The following is a description of a gene set: Genes having at least one occurrence of the motif GNCCAWATAWGGMN in the regions spanning 4 kb centered on their transcription starting sites. This matches the SRF transcription factor binding site V$SRF_Q6 (v7.4 TRANSFAC). Human Gene Set: SRF_Q6 studied in species Homo sapiens, and this is the list of marker genes: NOL4, LDB3, EGR1, TLE3, KCNK3, FGF8, TRDN, RSF1, SYNCRIP, SRD5A2, SRF, RASSF2, LPP, ADAMTS12, FLNA (NCBI Gene Id 8272), NPR3, ARPC4, TRAF3IP2, MYLK, DMD, PRMT3, DVL3, DUSP2, PRDM1, SLC25A4, DUSP10 (NCBI Gene Id 11221), EGR2, LRP5, FOSB, MAPKAPK2, NPPA, DMPK, EPHB1, CHD6, ACTB, FOXP2, BLOC1S1, STAT5B, NPAS4, ZNF513, NNAT, KBTBD12, KRT17, IGF2-AS, H2AX, ALG10, FAM53C, SVIL, THBS1, MUS81, HAPSTR1, RIMS1, RARB, ITGB1BP2, PDLIM3, FAM83H, ZNF408, ABR, GPR20, LYRM1, ZEB1, CTDSP1, TRIM55, DIXDC1, LSP1, PITPNA, H3-3A, SCN3B, PLPP3, HOXD13, MYL6, GRK6 (NCBI Gene Id 2870), TPM2, IGF1, TNMD, JUNB, CNN1, EML4, HOXC5, ATP1A2, FOSL1, ASPH, AKIRIN2, AGL, TRIM46, MYL1, TMEM47, MAP3K20, SIN3A, PADI2 (peptidyl arginine deiminase 2), MYL9, HOXD10, DCUN1D3, SIX2 (SIX homeobox 2), PLCB3, TAGLN, ACKR1, FGFRL1, RUNDC1, LINC00311, MRGPRF, COL1A2, PLN, PRKAB2, RHOJ, AARSD1, NFATC4, STX10, BDNF, GNG8, G3BP2, FLAD1, FOXP1, FOXP3, LDLRAD4, CITED2, SP7, ACTA1, PHF12, HIVEP3, SLC7A1, RAP1A, UBE2D3, ACTC1, ZNF644, ACTR3, HOXB5, NKX2-1, MSRB1, LRRFIP1, HERC1, ADGRG4, PRM1, ACAA2, KRTCAP2, CFL2, RERE, MYO1E, MSX1, KIF1B, RBBP7, FBXL22, DGKG, FST, SETD2, SUN2, CDKN1B (NCBI Gene Id 1027), CSMD3, PPP1R12A, TAFAZZIN, KDM3A, NPAS2, ACTN1, ABL1, ROCK2, NKX6-1, SLC4A3, CABP1, CNTF, PODN, JPH2, FOXE3, CX3CL1, SCOC, TMEM126A, TPM3, SIPA1, IL17B, PRUNE2, HOXA1, NR2F1, MYH11, RSU1, HOXA5, HOXA3, CD248, PDLIM7, LRRTM4, NAV1, MYO18B, ELAVL4, CSNK1E, LDHA, PPP2R3A, HOXB4, PRR14L, ORAI3, CKM, MBNL1 (NCBI Gene Id 9850), KCNMB1, ITGA7, KLF6, PRELP, TFAP2D, EVA1C, NR2F2, AAMDC, KCNA1 (potassium voltage-gated channel subfamily A member 1), TGFB1I1, ACTG2 (actin gamma 2, smooth muscle), MYADM, INSM1, EMILIN2, PDLIM4, GADD45G, POU3F4, EPB41L4B, PCDH7, AQP2 (NCBI Gene Id 359), PTCH1, CALD1, PDLIM5, MYL7, TES (testin LIM domain protein), CNN2, CORO1C, ATF4, SUSD1, RAB27A, PPARG, COL1A1, DUSP5, EFHD1, MATR3, CAVIN2 (NCBI Gene Id 8436), FOS, PFN1, CACNA1B, MAP1A, EGR3, H4C9 (H4 clustered histone 9), TADA3, NPM3, NR4A1, GPR158, STARD13, PICALM, WNT5A, TNNC1, MAP2K6, DHH, RRM1, RAI2, CFL1, NKX2-2, VCL, RASD2, ANXA6